The following is a description of a gene set: studied in species Homo sapiens Catalysis of an oxidation-reduction (redox) reaction in which NADH or NADPH acts as a hydrogen or electron donor and reduces a heme protein. Human Gene Set: GOMF_OXIDOREDUCTASE_ACTIVITY_ACTING_ON_NAD_P_H_HEME_PROTEIN_AS_ACCEPTOR, and this is the list of marker genes: CYB5R4, NQO1, CYB5R3, CYB5R2, COX15, NDOR1, CYB5RL, MTRR, AMBP (alpha-1-microglobulin/bikunin precursor), POR, CYB5R1